Given this list of marker genes Igf2bp3, Rps14, Rps7, Igf2bp2, Rps13, Rpl26, Rsl1d1, Aco1, Utp23, Dhx36, Larp6, Cct5, Igf2bp1, Larp1, Ddx3x, D1Pas1, Syncrip, Shmt1, Rpl5, Rara, Ncl, Gnl3, Fmr1 (NCBI Gene Id 207836), Myh10, Rps3a1, here is a description of the gene set: Binding to an mRNA molecule at its 5' untranslated region. Mouse Gene Set: GOMF_MRNA_5_UTR_BINDING studied in species Mus musculus